The following is a description of a gene set: Human Gene Set: HP_CENTRAL_DIABETES_INSIPIDUS Central diabetes insipidus A form of diabetes insipidus related to a failure of vasopressin (AVP) release from the hypothalamus. studied in species Homo sapiens, and this is the list of marker genes: PTCH1, CTNNB1, POU3F4, SHH, DISP1, GLI2, ZIC2, BRAF, CDON, STIL, DLL1, AVP, CRLS1, SIX3, TGIF1, FOXH1, NODAL, GAS1, WFS1 (wolframin ER transmembrane glycoprotein), FGF8, TP63, CRIPTO